The following is a description of a gene set: from publication Yevshin I, Sharipov R, Kolmykov S, Kondrakhin Y, Kolpakov F (PMID 30445619) studied in species Homo sapiens Human Gene Set: CHAF1A_TARGET_GENES Genes containing one or more binding sites for (CHAF1A) in their promoter regions (TSS -1000,+100 bp) as identified by GTRD version 20.06 ChIP-seq harmonization., and this is the list of marker genes: TRAPPC9, SUZ12P1, LINC01664, ZNF521, NUDT3, XPO7, USP3, ST20, ZMIZ1-AS1, ENPP3, PLEKHA8, WDTC1-DT, SYT7, MEMO1, HNRNPA2B1, MARVELD1, FABP5P3, PTEN, KMT2A, SSBP2, PADI1, WWP1, INKA2, MED23, DICER1, SLC39A10, CDYL, CITED2, INTS10, FOXK1, GPR137, ARID1A, IRAIN, KANSL3, CAPS2, IGF1R, ITGB1BP1, UBC, DAGLA, MFAP3L, GCLC, VPS36, SCAMP1, SGMS1, MRPS31P4, KMT2C, PPP6R1, SCAMP1-AS1, KDSR, CDYL-AS1, TAF2, BAD, ZMIZ1, CBX3, DICER1-AS1, FUT10, CENPU, MIR5188, PDE8A (NCBI Gene Id 5151), SGMS1-AS1 (NCBI Gene Id 104355295), MNT, ACOX2, SPRED2, SQSTM1, IARS2, TMEM121B, MIR7-3HG, LRATD2, FAAH, WWOX, TJP3, RN7SKP249, MGAT4B, SLC8A2, ALDH18A1, LNPEP, INO80C, MAML3, CPSF3, MKNK1, NSFL1C, ZNF609, EPS15, AIFM1, ZNF395, KCNJ4, GMPS, COX17, E2F6, WDTC1, HTR5A, ADGRL1, OSBPL1A, SMARCD2, INSR, ATP11A, MIR7-3, EPC2